Given this list of marker genes COPS2, RBMX, TXNL1, GPS1, RHOBTB1, SRRM1, ROCK2, MYO6, VIM, CPSF7, DBN1, STK38, CUL3, CCT2, PDE5A, HNRNPC, TRA2B (NCBI Gene Id 6434), COPS4, CCT7, ROCK1, RBBP6, RNF20, SPEN, here is a description of the gene set: studied in species Homo sapiens Human Gene Set: REACTOME_RHOBTB1_GTPASE_CYCLE RHOBTB1 GTPase cycle